Given this list of marker genes RAD9A (NCBI Gene Id 5883), CDC25A, CDC7, CDC45, CDC25C, ORC1, ORC3, RAD9B, RFC3, RPA2, MCM5, MCM3, RPA3, CDC6, MCM7, ATRIP, MCM2, DBF4, RAD17, ORC2, CHEK1, MCM4, HUS1, RPA1, RFC2, ORC6, CLSPN (NCBI Gene Id 63967), RFC4, ORC5, ORC4, RAD1 (RAD1 checkpoint DNA exonuclease), MCM10, RFC5, CDK2, MCM6, ATR, MCM8, here is a description of the gene set: Human Gene Set: REACTOME_ACTIVATION_OF_ATR_IN_RESPONSE_TO_REPLICATION_STRESS species: Homo sapiens Activation of ATR in response to replication stress